The following is a description of a gene set: Reactome Pathway: MAPK1 (ERK2) activation electronically inferred by orthology from the curated human pathway part of: RAF-independent MAPK1/3 activation species: Mus musculus This event has been computationally inferred from an event that has been demonstrated in another species.<p>The inference is based on the homology mapping from PANTHER. Briefly, reactions for which all involved PhysicalEntities (in input, output and catalyst) have a mapped orthologue/paralogue (for complexes at least 75% of components must have a mapping) are inferred to the other species., and this is the list of marker genes: Il6ra, Il6, Tyk2, Map2k2